The following is a description of a gene set: The process aimed at the progression of an enucleate erythrocyte over time, from initial commitment of the cell to a specific fate, to the fully functional differentiated cell. studied in species Mus musculus Mouse Gene Set: GOBP_ENUCLEATE_ERYTHROCYTE_DEVELOPMENT, and this is the list of marker genes: Rac1, Hdac6, Maea, Nemp1, Med1, Bloodlinc, Rac2, Diaph3, Trim58